The following is a description of a gene set: Marker genes curated from the annotated cluster as represented in the Descartes Human Gene Expression During Development database. from publication Cao J, O'Day DR, Pliner HA, Kingsley PD, Deng M, Daza RM, Zager MA, Aldinger KA, Blecher-Gonen R, Zhang F, Spielmann M, Palis J, Doherty D, Steemers FJ, Glass IA, Trapnell C, Shendure J (PMID 33184181) Human Gene Set: DESCARTES_FETAL_LIVER_LYMPHOID_CELLS The gene expression program underlying the specification of human cell types is of fundamental interest. The study authors generated human cell atlases of gene expression and chromatin accessibility in fetal tissues. For gene expression, the study authors applied three-level combinatorial indexing to >110 samples representing 15 organs, ultimately profiling ~4 million single cells. The study authors leveraged the literature and other atlases to identify and annotate hundreds of cell types and subtypes, both within and across tissues. Our analyses focused on organ-specific specializations of broadly distributed cell types (such as blood, endothelial, and epithelial), sites of fetal erythropoiesis (which notably included the adrenal gland), and integration with mouse developmental atlases (such as conserved specification of blood cells). These data represent a rich resource for the exploration of in vivo human gene expression in diverse tissues and cell types. species: Homo sapiens, and this is the list of marker genes: SLC4A10, SH2D1A, GRID2IP, IRF4, KLRC1, FCRL1, IL18RAP, CD3G, KLRC3, FAM111B, LEF1-AS1, SLFN12L, TIGIT, CD3D, NKG7, NIBAN3, AIRE, TCF4-AS1, FOXP3, PCED1B-AS1, IGKC, LCK, VPS37D, LINC01934, KLRC4-KLRK1, FCRL5, TCL6, HS3ST1, IGLL5, SLAMF6, VAV3-AS1, IL2RB, RORC, ALOX5AP, CARD11, TRBC2, FRG1JP, BCL11B, THEMIS, EPN2-AS1, CCR7, LINC02422, LINC02945, CD79A, CD160, IGHM, ADAMTS7P4, RASAL1, CD72, LINC00426, NCR1, KLRF1, LEF1, CD247, EBF1 (EBF transcription factor 1), IGLL1, BLK, LY9, MAP3K14-AS1, TRDC, LINC02202, FCRLA, CD8A, ADAM19, VPREB1, PTGDR, PYHIN1, LINC00861, CFAP73, VPREB3, IL7R, ANTXRLP1, P2RX5, FCMR, IKZF3, ITK, IKZF2, SLC8A1-AS1, IL23R, CD19, ENSG00000267568, JCHAIN, MYBL1, GRIK4, NMUR1, IGHD, LZTFL1, CLEC4C, GZMA, TCL1A, LTB, ENSG00000224610, CD96, GNLY, LINC01013, CD3E, HRK, KLRC2, FCRL2, RNU6-1214P, SH2D4B, SHISAL2A, ZNF831 (NCBI Gene Id 128611), ARPP21, RAG2, GZMM, RNFT2, MS4A1, RASGRP1, BACH2, POU2AF1, KLRB1, PRF1, CNR2, CD79B, PAX5, ZAP70 (NCBI Gene Id 7535), ENSG00000259097, DTX1, LAX1, SPIB, BLNK, DNTT, EOMES (NCBI Gene Id 8320), MME, ENSG00000254951, CD2, IFNG-AS1, ENSG00000229192, IL32